The following is a description of a gene set: Cytokines mediate cell-cell communication in the immune system and represent important therapeutic targets. A myriad of studies have highlighted their central role in immune function, yet we lack a global view of the cellular responses of each immune cell type to each cytokine. To address this gap, the authors created the Immune Dictionary, a compendium of single-cell transcriptomic profiles of more than 17 immune cell types in response to each of 86 cytokines (>1,400 cytokine-cell type combinations) in mouse lymph nodes in vivo. A cytokine-centric view of the dictionary revealed that most cytokines induce highly cell-type-specific responses. For example, the inflammatory cytokine interleukin-1β induces distinct gene programmes in almost every cell type. A cell-type-centric view of the dictionary identified more than 66 cytokine-driven cellular polarization states across immune cell types, including previously uncharacterized states such as an interleukin-18-induced polyfunctional natural killer cell state. Mouse Gene Set: CUI_CDC2_IFNK_RESPONSE_UP from publication Cui A, Huang T, Li S, Ma A, Pérez JL, Sander C, Keskin DB, Wu CJ, Fraenkel E, Hacohen N (PMID 38057668) Genes positively differentially expressed in cell type: cDC2 (conventional dendritic cell type 2) upon treatment with cytokine: IFN-κ in mouse lymph nodes in vivo. species: Mus musculus, and this is the list of marker genes: Nampt, Ifit1, Fcgr1 (Fc receptor, IgG, high affinity I), Gmppb, Psmb10, Parp14, Ifi213, Ly86, Grn, Znfx1, H2-T23, Oasl2, Xaf1, Oas1a, Fgl2, H2-T22, Rtp4, Ifi207, Tmbim6, Slfn2, Oas3, Rab18, Ddx60, Uba7, Samhd1, Icosl, Calm1, Sct, Adar, Ms4a6c, Ascc3, Ifitm3, Bst2, Phf11d, Tor1aip1, Zbp1, Unc93b1, Trim30d, Mpeg1, Trim12c, Marcksl1, Herc6, Usp18, Rigi, Slfn1, Efhd2, Parp12, Eif2ak2, Kdr, Fcer1g, Tgfb1, Phf11a, Ly6a, Cxcl9, Isg15, Mitd1, Psmb8, Ms4a6d, Tspo, Ube2l6, Ifit2, Spi1, Hspa8, Iigp1, Zfand3, Lgals3bp, Psme2, Stat1, Rnf213, Ifi27l2a, Ccnd1, Ly6e, Ifi47, Tapbp, Ifit3, Stat2, Grb2, Trim30a, Lgals9, Axl, Gbp7, Gbp9 (NCBI Gene Id 236573), Tcof1, Clec2d, Ifi211, Slfn8, Isg20, Mndal, Oas2, Mlkl, Ms4a6b, Epsti1, Xdh, Rsad2, Irf7, Il1rn, Npc2, Slfn5, Sp110, Cd52, Ppp1r15b, Gbp2, Trafd1, Sdc3, Sppl2a, Pnp, Nmi, Adap1, Ifi35, Ptpn6, Cyrib, Dhx58, Ifi209, Sp100, Ifi203, Ubc, Pdgfb, Ifi206, H2-D1, Parp9, Ifih1, Ms4a4c, Trim30b, Lfng, Cxcl10, Irgm1, Trim34a, Ifit3b, Phf11b, Selenow, Ass1, Ifi204, Hck, Igtp